The following is a description of a gene set: Impairment of the complex regulatory network of cell death and survival is frequently the reason for therapy resistance of breast cancer cells and a major cause of tumor progression. We established two independent cell lines from a fast growing mouse breast tumor (WAP-SVT/t transgenic animal). Cells from one line (ME-A cells) are sensitive to apoptotic stimuli such as growth factor depletion or treatment with antitumor agents (e.g. doxorubicin). Cells from the second line (ME-C cells), which carry a missense mutation at the p53 codon 242, are very insensitive to apoptotic stimuli. Co-cultivation experiments revealed that the ME-C cells mediate cell death resistance to the ME-A cells. Microarray and Western blot analysis showed that osteopontin (OPN) is selectively overexpressed by the ME-C cells. This glycoprotein is the most abundant protein secreted by the ME-C cells and we obtained strong indications that OPN is the main antiapoptotic factor. However, the OPN containing ME-C cell medium does not alter the expression level of pro- or antiapoptotic genes or known inhibitors of apoptosis (IAPs). Its signaling involves mitogen-activated protein kinase (MAPK)/extracellular signal-regulated kinase (ERK) kinase (MEK)1/2 as the kinase inhibitor PD98059 restores apoptosis but not the Akt inhibitor. In the ME-A cells, mitochondrial cytochrome c release occurs with and without external apoptotic stimuli. OPN containing ME-C cell medium does not prevent the mitochondrial cytochrome c release and caspase-9 processing. In serum starved ME-A cells, the OPN containing ME-C cell medium prevents caspase-3 activation. However, in doxorubicin-treated cells, although apoptosis is blocked, it does not inhibit caspase-3. This indicates that the ME-A cells distinguish between the initial apoptotic stimuli and that the cells possess a further uncharacterized control element acting downstream from caspase-3. Genes down-regulated in ME-A cells (breast cancer) undergoing apoptosis in response to doxorubicin. Human Gene Set: GRAESSMANN_APOPTOSIS_BY_DOXORUBICIN_DN studied in species Mus musculus from publication Graessmann M, Berg B, Fuchs B, Klein A, Graessmann A (PMID 17160024), and this is the list of marker genes: KNSTRN, PDHA1, PORCN, CPT1B, HSPB8, TAF1D, CTDSP2, EID1, MAPKAP1, CCDC127, SNRNP48, INSIG2, SUZ12, REEP6, PRMT2, PPDPF, FRMD4B, SPEG, TOP2A, PUM2, IP6K1, ANXA6, SMR3B (submaxillary gland androgen regulated protein 3B), FDFT1, NAGK, NUDT21, TAOK1, KLF3, ZNF429, ZNF212 (zinc finger protein 212), DUSP11, CHST10, WASL, NREP, IFRD2, OSGEP, C11orf98, PTCH1, LRRC8C, PAFAH1B1, APEX1, ZNF18, CFAP97, MRGPRF, CAB39L, KLF7, TRIP4, ZFP91, FECH, NFATC1, RIMOC1, UBE2J1, CNOT6L, INVS, KRTCAP2, CXXC1, HLF, ZNF644, FMR1, ZMYM3 (NCBI Gene Id 9203), OSR1, EFNA4, PBX1, BCL2L2, SNAPIN, ARMCX1, ARHGAP21, TTC8, GHR (growth hormone receptor), TBCE, PPIL4, ARGLU1, COMMD2, WEE1, MRPL40, ADAT2, TFB1M, NR3C1, PTRH2, CD2AP, ZBTB7B, VCF1, PLEKHA5, CXCL6, MND1, DTX3, CERT1, NOP58, PIK3C2A, PTRHD1, ZNF22, MSH3, GATD3, ITGA5, MDP1, MRRF, MINPP1, PCBP4, RNF130, RPL22, FOXC1, DRG1, TRIP11, NDFIP1, BICD1, NUDCD3, THOC2, LIMS1, C6orf136, ALG14, TM9SF3, EXOSC5, MTSS1, FANCL, ERCC4, MFSD4B, ZBTB14, TRIM44, PALS2, FUBP1, ZNF207, PCMTD2, DLGAP5, DOCK1, UBAP2L, SAE1, INTS7, TTC14, TOMM40, CTBS, ERBB2, PLPP3, SCARA5, NFKB1, METTL1, TMEM268, NFYA, SPTBN1, RHOBTB2, HIPK2, CARD19, DUSP16, MDN1, LMNB1, UQCC2, USP9X, RACGAP1, SRPK2, GORASP2, PHF13, GNG5, GHDC (NCBI Gene Id 84514), DHX9, IL1R1, POLR1HASP, OSMR (oncostatin M receptor), DNAJC24, CEP152, SOX6, GALK1 (NCBI Gene Id 2584), ZNF322, SLC9A8, SNHG8, DYNLT1, EXOSC2, MTHFD2, TFAP4, FOXJ3, UBE2G1, YWHAH, MRPS5, STX12, ACAA2, TRPM7, THAP12, CHAC2, NFATC3, EXOC6, NCK2, STAMBPL1, IGFBP2, CAV2, NIPBL, VTI1A, CADM1, SLC25A13, SNHG6, CNN3, ARL6IP5, TLCD1, LRRC58, TUBA1A, FRYL, GLI2, PPARGC1B, ATXN7L3, CLSTN1, FOSL2, HNF4A, PEAK1, TP53I13, PRIM2, GRTP1, BMPR1A, COQ5, EEF1E1, RPP40, SMIM10L1 (small integral membrane protein 10 like 1), FBXO6, PSTK, TBL1X, XPO4, OXSM (3-oxoacyl-ACP synthase, mitochondrial), PRKACB, OGG1, CYP4F8, DCAF5, SENP6, TNPO3 (transportin 3), BRAF, KIF1B, RUFY3, PFKP, PGLS, FARP1, TPBG, KANK2, MSN (moesin), ROR1, CHD1L, PASK, ANAPC11, RNF111 (ring finger protein 111), ADAMTSL5, ODR4, PER3, MTBP, ATP5MC2, PYGB, LCLAT1, MED16, NT5C3B, MAD2L2, HELLS, STAM2, PANK1, MYO1B, PDZRN3, PBX2, TSPAN5, ITCH, GPR137B, MOSPD2, IPO8, SPHK1, STAG1, IKBKG, TRIB3, VANGL1, MKI67, BRI3, RIF1, LTBP1, OXA1L, TUBB, MUTYH, PHF21A, NELFA, YES1, ACHE, PARD6A, CHD4, ATAD1, OSBPL6, C16orf74, RNASEH1, SLC44A1, NRP2, RNGTT, PIGC, RUSF1, NF2, P2RX4, FRRS1, HMGB1, FYN, MED12, AOC3 (amine oxidase copper containing 3), MID1IP1, PCDHB18P, ASNSD1, PABIR1, UBR5, FARSB, FIGNL1, TACC2, RBL1, CCNH, SLC6A2, HIKESHI, BCKDHB, CSDE1, CLPP (caseinolytic mitochondrial matrix peptidase proteolytic subunit), DCUN1D1, DHCR24, VPS35L, SFXN4, PSENEN, RCC1L, RCAN3, UBA3, FKBP11, KAT7, ARPC1B, POLD2, SUPT20H, ADAM17, AMZ1, HNRNPL, CLIP1, ANAPC4, TADA3 (transcriptional adaptor 3), H1-4, WASHC4, MRPL3, POLD3, PAK3, FANCC, COL3A1, NUP133, DBF4, EMG1, SEPSECS, SRGAP2, CDK5RAP2, KITLG, C1QTNF12, SNRPA, WWOX, ELF5, ACACB, PCCA (propionyl-CoA carboxylase subunit alpha), RPA3, SLAIN2, CCDC43, ACTR8, PLEKHG5, PPP1R3C, KPNB1, ARID4B, COQ3, TLE2, RCE1, GJC1 (gap junction protein gamma 1), NCAPG2, IGF2BP2, MAN1A2, EPC1, ATP10A (NCBI Gene Id 57194), AATF, OGT, KLHL36 (kelch like family member 36), ZEB2, CCDC50, RAI14, PMPCB, CCNI, TPM3, MAGI3, FAR1, JTB (NCBI Gene Id 23561), HEXD, ACVR1, OPA3, POLM, ARHGAP5, PLEKHF1, WDR33, RBMS1, CHMP1B2P, RGS11, FTO, OSBPL9, TMEM176A, BCCIP, PPAT, TMEM80, ZBTB17, CELA1, MSRB2, SERTAD3, ACOT9, DTYMK, UTP25, THSD1, TNNC2, TWF1, IVNS1ABP, REPS1, DOCK9 (dedicator of cytokinesis 9), POLR3A, MTFMT, XPO7, LUC7L2, IL6ST, TCF7L2, TGFB2, PTBP3, TMEM168, EEF2K, CZIB, ETF1, ELK1, RITA1, HBP1, SERGEF, SPRED1, DDX6, CRK, ARRB2, JDP2, CETN3, KLHL5, RAB3D, CBX3, ZNF277, YEATS4, ACBD6, COQ8A, RAB27B, ENC1, TUBGCP4, KPNA3, RPP14, PSIP1, SMIM30, GNG12, COA5, COP1, LETMD1, CHCHD3, NRM, PTBP2, RANBP1, ATP6V0A1, FRS3, DMAC2, KRBA1, RREB1, CRADD, ZBTB46 (zinc finger and BTB domain containing 46), THOP1, PDGFRA, DYRK1A, DDI2, SDC3, BOLA1, PAFAH1B3, TRUB2, CBX5, SNX18, MRPS28, ADNP, LMF1, MCCC2, RFK, C5orf34, EWSR1, DDX3X, GEMIN6, CARM1, NSMCE2, SKP2, CLOCK, KMT2E, RPL41, PCGF2, MYC, RPL30, UBE3A, ADISSP, MPC1, THA1P, CUL4B, TRIM2, CD44, IARS1, RBFOX2, PHB1, MSMO1, ORC3, TBRG4, UTRN, SH3BP5, ZNF282, ZSCAN21, STAT5B, TRPS1, NUDT16L1, PIGO, JMJD8, CXADR, ZNF771, CHM, PER2, HDAC7, POLR1D, AHDC1, APBB1, GOLIM4 (golgi integral membrane protein 4), KRAS, SARNP, RRP1B (ribosomal RNA processing 1B), AARSD1 (alanyl-tRNA synthetase domain containing 1), DIABLO, ILKAP, STRADA, MRPL19, EHD2, EGLN2, NUBP1, NUMB, GTF2IRD1, CKAP5, PDGFRB, BBS9, SPRY1, UBE2E2, DLG1, MMACHC, DYSF, NTNG1, XRCC4, ZNF768, CBX8, FBXO4, ZBTB20, MYOD1, CRYZL1, GNA12, NFIX, DST, POLR1H, NECTIN2, CNOT7, URI1, CNOT2, PKP4, CPTP, TCP1, VSX2, MGST3, PEX7, TRIM16 (tripartite motif containing 16), S100B, HSPA8, GPATCH8, NUSAP1, FJX1, TRMT112, STOML2, SESN1 (NCBI Gene Id 27244), RNF138, EIF4B, PCID2, BORCS5, TOMM5, MAP3K5, TMEM161A, NEURL4, SLK, TRAF6, KLF6, SPCS3, PRPF39, HERC4, HNRNPR, ATP5MC1, ATG5, TCF25, RP2, POLR3F, ELOVL6, MYO10, PPP3CA, ATM, SSPN, FBXO21 (NCBI Gene Id 23014), KLF13, ABCD3, CAMK2D, SFR1 (NCBI Gene Id 119392), SPPL3, NASP, MYDGF (NCBI Gene Id 80302), TIFA, GABBR1, RSRC2, SON, D2HGDH, ITGB3BP, SMC5, TMEM60, SNORD22, GRK5, KIAA0319L, FOXF2, MIOS, POLR3G, ZNF704, BIRC6, MAPK8, CDK5RAP1, BABAM2, NEDD4, ERG28, NCOR1, NEAT1, SVIL, TFRC, GSR, HSPA4, PABPN1, TSEN15, HMGXB4, AMBRA1, RBM39, CUL3, SMAD4, ZNF235, TARS2 (threonyl-tRNA synthetase 2, mitochondrial), LACTB2 (lactamase beta 2), ZNF318 (NCBI Gene Id 24149), NF1, CCNT2, SEC14L1, LRCH4, ELOVL5, GPAM, WDR4, VAV3, CXorf38, GPHN, ZNF638, AK3, PALM2AKAP2, DNM1L, EEA1, FER (FER tyrosine kinase), TCERG1, STEAP3, SAAL1, POLD1, NDST1, THRA, GABRB2, CLIP2, CEBPG, FADS1, KRCC1, COL12A1 (collagen type XII alpha 1 chain), CEP20, PPP1CC, MARCKS, ASB7, TRIO, COL5A2, HMGA2, MYOC, PRKCZ, CAPZA1, TMEM167A, XBP1, DHRS4, SBF2, TYMS, MAP3K4, RILPL2, ARHGEF12, TCF3, SPAG7, CBX1, RAB2A, HADH, NRAS, ITSN2, WDR82, RPAP2, TSPAN15, ZNF521, ALDH1B1, PNN, CEP131, SUV39H1, AFG3L1P, MYL6B, RBM18, CDC42BPA, TMEM106B, HECTD1, ACSL4, GEMIN2, DYNLT3, MKKS, RNF13 (ring finger protein 13), SPEN, LANCL2 (LanC like glutathione S-transferase 2), BCL7B, MPDZ, TSPAN2, PIK3C3, PRUNE1, NR1D2, LOXL4, SRSF10, HNRNPA1L2, LMBRD1, ZMYM6, HNRNPK, NRF1, COIL, COL1A2, USP4, ATG10, XPA, SERPINB1, BNIP1, FOXP1, MTMR4, RASSF8, RBBP9, MRPS16, PCF11, YWHAZ, NFIC, USP47 (NCBI Gene Id 55031), PAPSS1, SLFN12, CD276 (NCBI Gene Id 80381), LYRM2, CBL, AP1G1, EIF4A2, DENND1A, SPIN1, ALKBH4, NKD2, PHF3, KCNK1, RDH14, ZSCAN12, SKI, MYG1, TRAF2, SNX9, IL17RC, SLC9B1, GOLPH3, DLX5, NOP10, CNOT4, WAC, CLCF1, MAP2K7, FAM118A, PLCE1, BNIP3 (BCL2 interacting protein 3), DCPS, C19orf53, INTS6 (integrator complex subunit 6), KANSL2, MORF4L1, PTPRF, COG1, HOMER2, SF3B3, PLD2, RIPK1, PRPF31, CAMK2G, ZFP90, BCR, SRSF3, GLG1, CCDC102A, RYK (receptor like tyrosine kinase), AP5M1, TRIP13, DCLK1, ANLN, UBE4B, SMARCA2, MCRS1, AGFG2, MED25, PIPOX, PRELID1, ELK4, RUNX2, EFNA5, COA7, SPDEF, MYNN, BEAN1, IGFBP5, SLC39A11, SC5D, APBB2, ATXN7, PAFAH1B2, BICC1, SLC20A2, SMIM11, RPP21, SNX15, NEK7, IGF1R, TRIB1, GABPA, MRPL12, SND1, AGAP1 (NCBI Gene Id 22851), HNRNPD, ATL3, ACVR1B, RAB4A, U2AF1L4, TARS1, HTATSF1, EEF1AKMT1, NAP1L3, SFXN1, HAUS1, DCP1A, PRNP, TMEM121, RAB4B, ALG3, DDX10, RETREG1, PHIP, NDN, LIMK1, EIF4E2, PARN, SOX12, CRELD1, CA9, DUSP19, TMPO, ENOX2, TNRC6B, PAXIP1, MRTFA, PUM1, EXOC4, RNF145, TUBB2B, GDI1, GRB14, QRICH1, WDR75, VRK3, HNRNPU, EXT1, ATXN2, CYP1B1, F2RL1, ZNF148, KDELR1, CEMIP2, NONO, LGALSL, SIRT4, SLC4A3, KANSL1, LIG3, RSRC1 (arginine and serine rich coiled-coil 1), EGLN1, GDPD1, GALNT2, TBC1D19, WDR77, ZNF280C, HMBS, ADAT1, ATE1, COPG2, GALNT4, EIF4A1, COPS7A, ARMT1, BCS1L, RNF214, DMP1 (NCBI Gene Id 1758), CNTF, SHKBP1, GAS5, PLIN3 (perilipin 3), MTCH2, PDE7A, SPATS2, DAP, CEP57L1, MDFI, SEH1L, TMEM39A (transmembrane protein 39A), IARS2, SLC39A3 (solute carrier family 39 member 3), TRPC2, CACHD1, SCAF8, BEX3, PHKA2, TXNIP, FZD2, YBX3, KAT2A, RUSC2, ATP9A, PURA, COX17, TRAK1, EFR3A, KLHL24, VWA1, SLC7A2, CALM3, PRELP, PPP2R3A, CDCA7L, DARS1, RRM1, ZNF142, CUL2, DPY30, PRMT7, NSMCE1, CASD1, WNT5A (NCBI Gene Id 7474), BACE1, MBOAT1 (NCBI Gene Id 154141), KIAA1217, HSPA9, ADAMTS5, HJURP, ZFP82, RRP15, DCAF1, SRGAP3, FARS2, USE1, VANGL2, ERC1, CLYBL, ANGPTL6, DPH6, CCDC88A, SNX14, IL13RA1, DMAC1, PFKM, MLLT10, CCNQ, EDEM3, WDR87, ST7L, MCM2, H1-0, FLOT1, ZBTB22, CDKN1B, MTHFS, PIMREG, BCL9, NDUFB4, DDR2 (NCBI Gene Id 4921), COL4A6 (NCBI Gene Id 1288), HIBCH, CDC27, GRHL2, CCSAP, GALNT7, DIMT1, PHLDB2, RLIM, SREK1, TPR, SLC23A2, SRPRB, BCLAF1, STAT6, PLA2G15, NET1, EPN2, MORF4L2, CEBPB, GYS1, ZNF398 (zinc finger protein 398), TGFBR3, CDCA7, ATP5F1C, MAPT, POLA1, EPHA4, RAD18, DRAM2, MAP3K1 (NCBI Gene Id 4214), LPP, SKA1, NORAD (non-coding RNA activated by DNA damage), BBS2, GSK3B, RBM26, HNRNPDL, MRPL23, SULT2B1, GATAD2B (NCBI Gene Id 57459), MTMR2, CTNNBIP1, TMEM176B, OXNAD1, CTTN, HSPBP1, PRPF38B, RHOT2, PTPN21, UQCC4, ITPR1, ASAP1, DHCR7, TENT2, MRM1, TIMELESS, GPT2, SPRED2, PAPOLA, CNTLN, BCKDK, TOE1, FXN, CYP24A1, XPR1, PANK3, ABCE1, AQP5, SIN3A, KIF4A, PDSS1, TCF4, ABCB7, POLR2I (NCBI Gene Id 5438), CDKAL1, NUP160, GMFB, DPAGT1, LSS, MAGOHB, THRSP, SPART, EFL1, KAT2B, ANKH, DCAF8, USP22, MEF2A, VASP, P2RY2, PLSCR1, JARID2, COX16, PQBP1, FNDC4, RHBDD1, BCDIN3D, TAFA5, HDAC3, ZNF790, RNF141, SH3KBP1, EMP2, UBXN6, VPS54, MAP4K3, ARFGEF1, ME2, FRMD6, CSNK2A1 (casein kinase 2 alpha 1), SASH1, CNOT6, ATP11A, LYPLAL1, APOOL, ATF6, CTDSPL, RABGGTB, GSDME, NAGA, FGFR1, PRKD3, NUDT2, FDPS, NAA15, EMP1, PDAP1, PCNX3, ALDH18A1, PTOV1, CHEK2, SP3, TPD52L2, FUOM, SGTB, ELP3, DOCK5, KDM4B, TIMM10, ZFAND3, TMEM175, OCEL1, MS4A8, MAPK3, NDUFS7, MRPL42, THRAP3, TF, FBXL8, SMARCB1, SLC4A4, ELAC2, TBL1XR1, SNHG5, NFYC, DCTN4, ELAC1, CFAP141, PPP2R1B, SEPTIN10, SQLE, FOXM1, ZNF292, PRXL2C, PDK1, CDC6, LRBA, NCAPH, CYB5B, LDLR, EVA1A (NCBI Gene Id 84141), RPS19, ZBED3, NAA10, CHML, DHODH, SPOP, NSFL1C, C1orf159, BAZ2B, MARCKSL1, CD200, ZNF329, TLR6, ATRX, ZCCHC7, MEPCE, ATP2A2, AHCTF1, PRKDC, NXT1, FANCA, HMGCS1, MNT, ZSCAN26, DAZAP1, RAD51C, ASPH, ETS1, NUP107, PARD6B, CCN5, RPL22L1, ATF2, PTPRK, SSBP1, RBM25, BRAT1, HARS2, TOM1L1, HMBOX1, TNRC6A, CPNE1, NR2C2AP, KCTD1, COX20, TANC1, SINHCAF, PAGR1, IQCC, RAVER1, BOC, DBN1, UCK2, HCFC1, AKAP12, VTI1B (vesicle transport through interaction with t-SNAREs 1B), EFHD1, NUF2, FBXW2, CDC7, HDHD3, MTAP, FASTK, NRIP1, DHX36, CRYBG3, ATP1A2, SEC24D, NBEA, GATB, CASP2, CRLF2, IPP, DHRS11, STK3, ZSCAN22, FBXW11, FOXN2, PTPRS, ANKRD17, SLC29A2, CYB5R1, SPTAN1, POLE2, CYP51A1, IER3, STX8, SNAI2, RBM10, ADK, KMT2A, XIAP, SLF2, RBM14, TCF19, SRGAP1, SCAF11, MTMR3, GNL1, IL15RA, POMK, FOXF1, DNAJC14, ID3, ACTB, CNTROB, USP21, DGCR8, CDC73, MTDH, RASSF1, NMT1, PARD3, CEP41, PMF1, DLK2, CCL5, UBA2, HSD3B7, CHEK1, EIF5B, CSTF2, ACIN1, LPCAT1, TPK1, ARIH1, C1QBP, CAP1, PDK2, ZNF706, PAK1, FSTL1, TAF8, VAMP3, PAICS, SLC12A6, TBC1D17, ZNF467, PTCD2, EPB41L4A, UBL4A, RAB28, LMBR1, SRSF7, TSC22D4, ZNF607, PIK3R1, NOTCH2, STC1, PDS5A, FERMT2, ZNF280D, NEDD4L, IGF1, MUC4, KLHL20, OPHN1, TRIB2, PRPSAP1, NUDCD1, RMND1, KMT2C, FANCM, CSNK1D, IDE, DENND11, AKAP8, NSUN4, SUCLG2, MVK, UBE2S, TMEM209 (NCBI Gene Id 84928), TRDMT1, VPS72, EXOSC1, AP3M2, DUSP12, TIMM44, KLHL7, SRSF2, DDX19B, DNAJC13, RASL12, MAP6, LAMC1, PTPN11, PEX14, SH3RF1, MBD3, YTHDF3, NDUFAF7, NUP58, HEATR1, POLE, ERI3, DGCR2, DLAT, ADCK1, IPO11, BBX, ZKSCAN3, RAF1, SRSF6, ALG12, RGS19, SREBF2, MRPL50, PTDSS2, SCAMP4, C1D, RAD23A, NT5C, KEAP1, LIMCH1, MAP2, MYADM, SESN3, SMARCAD1, POLR1A, MBD2, PEX11A, PPP2R3C, SOCS6, MCMBP, ARHGEF10, SLC19A1, MAGI1, BET1, UBE2C, LMNB2, CCDC91, MDFIC, GMNN, TMEM126A, EPB41L2, GTPBP2 (NCBI Gene Id 54676), ST13, MYBBP1A, DDX17, KMT5B, FAM220A, ISOC1, ELK3, E2F8, PARP16, IKBKB, ARF6, BPNT1, MLLT3, RAD51B (RAD51 paralog B), PLPP2, FAIM, ABCC1, CGNL1, LYST (lysosomal trafficking regulator), PDE8A, NISCH (nischarin), DSG2, ATP6V0A2 (ATPase H+ transporting V0 subunit a2), SOCS2, EARS2, PPIH, CHD1, KIF11, FBF1 (NCBI Gene Id 85302), TMEM109, ANP32B, LTA4H, NSMCE4A, OLFML2B, PLA2R1, DTL, TMEM144, POLB, FAM3C, BORCS7, PLP2, GMPR, MPHOSPH10, RABGGTA, C11orf52, NICN1, LGALS7, STEAP4, SUOX, MRPL34, CASK, STARD4, RRBP1, SLC25A10, MTF2, NUTF2, BTC, HIF1A, CARMIL1, SMYD2, UBR2, RALGAPA1, POLI, PTPRA, CIP2A, POLR1B, SNHG16, HSPE1, RABIF, CDK16, CNOT1, SLC30A6 (solute carrier family 30 member 6), TNS2, DUSP22, GAB1, DDX39B, PHF20, IMMT, ZCCHC8, CMBL, LZTS2, SLC25A24, WDSUB1, SLC44A2, IBTK, KIF3C, STAT5A, USP36, ROCK1, PTMS, SYNCRIP, ASH1L, XPO1, EXOSC7, EFHD2, FASTKD2, ANAPC1, ERBIN, CAVIN3, NDUFAF4, BGN, MRPL17 (mitochondrial ribosomal protein L17), ZFPM1, C17orf49, CTDSP1, MYOF, TCP11, TMEM216 (transmembrane protein 216), TMEM79, TTC5, CSTF3, TNFSF13, KHDRBS1, BRCA2, NOLC1, SNRNP40, CAV1, PFKL, HUWE1, STX4, ZCCHC14, METTL27, TMEM179B, DCTPP1, WDFY3, EXOSC10, LRP6, CLASP2, GNB1, EZH1, HMGB2, TTYH2, SSR1, C15orf40, ZDHHC6, CUTA, ATF4, GID8, ARHGEF10L, CACNA1A, SMARCE1 (SWI/SNF related, matrix associated, actin dependent regulator of chromatin, subfamily e, member 1), TCF12, HACE1, KIF2A, TCOF1, TMEM135, MAP4K5, GART, ELP2, ROCK2, FADS2, USP1, PIGU, EBPL, RCL1, PSMG1 (proteasome assembly chaperone 1), GCSH, PHKA1, PCM1, PPP4R3A, MRPL32, MNAT1, CREB1 (NCBI Gene Id 1385), ALDOA, ST3GAL1 (ST3 beta-galactoside alpha-2,3-sialyltransferase 1), LOX, EPHB4, PCBD2, AAK1, MBTPS1 (membrane bound transcription factor peptidase, site 1, NCBI Gene Id 8720), TCTN3, UFC1, CASC3, KPNA1, CENATAC, STX17, FAAH, ELMO1, PIGP, TEN1, TIA1, LYSMD3, BTBD3, HIVEP2, CILK1, VCAM1, PPP3CC, AKR1E2, SWAP70, AP3D1, RCCD1, MECP2, NDUFS8, BYSL, CTNNB1, LAMTOR4, ADAM10, BLOC1S5, H2AC8, RAD23B, MRPL58, PBK (NCBI Gene Id 55886), TLE6, CYP2C18, CNEP1R1, RDX, GTF2I, PCMTD1, MYO1E, ST3GAL5 (NCBI Gene Id 8869), ELP4, ERGIC1, MMAB, COMMD1, FKTN, ANGPT1, CDK4, SOD2, DIAPH3 (NCBI Gene Id 81624), ERCC6L, SEMA6D, PARP2, TBL2, TTI2, DTNBP1, METRN, TENM4, UBE2W, DAGLB, IRF3 (interferon regulatory factor 3), B9D2, SLC35A3, RFC1, AP2B1, TIMM9, RAD21, SMYD5, NOTCH4, RTTN, RILPL1, PSMG4, BRD4, QKI, NR2C2, LBR, SENP1, HIP1, UBE2E3, SRSF1, NPM1, TDP1, C11orf58, SH3BGRL, SCD, BCL2, RPL3, NOP56, ABHD17C, TIMP3 (NCBI Gene Id 7078), NCAPD2, SIL1, EIF2S2, SNX5, KICS2, CDK2, RAB9A (NCBI Gene Id 9367), PPP4R3B, PUS3, RUNX1, ERLIN1, COASY, NFIB, HP1BP3, DNA2, PTS, POU2F1, ECI1, TRMT1L, ZNF395, BRCC3, BRD8, MAPRE2, ORMDL1, FEZ2, METTL22, PHYKPL (5-phosphohydroxy-L-lysine phospho-lyase), BNIP3L, GNPNAT1, SLC44A3, TXNRD3, CLK4, PDE6D, RAB18, ARHGAP6, MRPL15, CAPRIN1, SEC16B, KRI1, PBRM1, RABGAP1L, RAD54L, ZBTB12, TMEM186, TOM1, RECK, FZR1, DNAJB12, TK1, ZNF445, CNTN1, KIF5B, BCL3, PLD1, STAG2, XRCC5, NR1I3, CAPN6, MGA, MYORG, TEFM, UBR1, PUM3, HSD11B1, ADD3, GCNT1, POT1, EFCAB2 (EF-hand calcium binding domain 2), PHF12, TMLHE, UBE2K, RAB14, RRP8, UBE2D3, YAE1, NT5E, DEPTOR, CTCF, CCDC9, NEK3, C2orf76, CEBPZOS, GOT1, ZFHX3 (zinc finger homeobox 3), DYM (dymeclin), MYO9A, DEK, PLK4, INPP5K, BRWD1, GNAO1, FOXK2, CBX6, FMO1, PTPN12, MSRA, DIP2B, TTC28, ANKRD13B, DHPS, RAP1GDS1, DHDDS, REV3L, SMC6, IFT46 (NCBI Gene Id 56912), RBM5, CEP15, CHD7, ZDHHC5, DNPH1, BIN1 (bridging integrator 1), ILF3, RHOU, ENSA, NEIL3, OLA1, USP34, MYB, ERI2, FUT8, PITPNB, CAT, PCK2, TRIL, ZDHHC3, BAG5, POFUT1, NUDT4, IFT122, TTC3, ETAA1